Given this list of marker genes PDXDC1, ACOD1, GADL1, CSAD, BCKDHA, ALDOB, SHMT1, GOT1, AZIN1, MVD, HMGCLL1, PCK2, ODC1, GAD1, OAZ3, HDC, PCK1, TYW1, HOGA1, ALDOC (NCBI Gene Id 230), ME2, ARMT1, PPCDC, NPL, CRY2, CLYBL, SHMT2, HACL1, TYW1B (NCBI Gene Id 442576), DERA, ME3, HMGCL, MLYCD, DDC, MOCS1, OAZ2, SGPL1, UMPS, URAD, PARK7, UROD, DDT, PDXDC2P-NPIPB14P, ME1 (NCBI Gene Id 4199), PAICS, AZIN2, UXS1, COQ4, FAHD1, AMD1, GGCX, GAD2, OAZ1, ALDOA, PISD, CRY1 (cryptochrome circadian regulator 1), ECHDC1, ACMSD, here is a description of the gene set: Human Gene Set: GOMF_CARBON_CARBON_LYASE_ACTIVITY Catalysis of the cleavage of C-C bonds by other means than by hydrolysis or oxidation, or conversely adding a group to a double bond. species: Homo sapiens